Given this list of marker genes CYP4A22, CYP4F2, CYP2U1, CYP4A11, CYP4F11, CYP4F3, here is a description of the gene set: Human Gene Set: GOMF_ARACHIDONATE_OMEGA_HYDROXYLASE_ACTIVITY species: Homo sapiens Catalysis of the reaction: (5Z,8Z,11Z,14Z)-eicosatetraenoate + O2 + reduced = 20-hydroxy-(5Z,8Z,11Z,14Z)-eicosatetraenoate + H+ + H2O + oxidized. (5Z,8Z,11Z,14Z)-icosatetraenoic acid is also known as arachidonic acid is also and 20-hydroxy-(5Z,8Z,11Z,14Z)-eicosatetraenoate as 20-HETE.